The following is a description of a gene set: The presence of an increased number of freckles, small circular spots on the skin that are darker than the surrounding skin because of deposits of melanin. species: Homo sapiens Freckling Human Gene Set: HP_FRECKLING, and this is the list of marker genes: CDKN2B, ACD, SPRED1, TP63, KRT5, RAF1, KAT6A, POT1, MSH6, ERCC3, MC1R, CDH3, XPC, MGMT, NF1, TYRP1, ERCC4, TYR, ERCC2, AP3D1, BAP1, MITF, PPP1CB, NBN, POFUT1, SASH1, CDK4, PSENEN, CDKN2A, GPR143, OCA2, XPA, ERCC8, HPS1, ABCB6, DDB2, TERF2IP (TERF2 interacting protein), ERCC5, PRKAR1A, SOX18, BRAF, UVSSA (UV stimulated scaffold protein A), MLH1, NF2, POGLUT1, TERT, ERCC6, PTPN11 (protein tyrosine phosphatase non-receptor type 11)